The following is a description of a gene set: Any process that modulates the frequency, rate, or extent of leukocyte migration. studied in species Homo sapiens Human Gene Set: GOBP_REGULATION_OF_LEUKOCYTE_MIGRATION, and this is the list of marker genes: SPI1, MICOS10-NBL1, IL34, CD99, MIF, SLIT2 (NCBI Gene Id 9353), THBS4, GPSM3, GDF15, SMPD3, IL1R1, DAPK2, CXCR3, ADA, PIK3R1, CD81, F2RL1, RHOA, GAS6, PYCARD, DEFB124, MDK, F7, EDN3, GCSAML, CCL5, GCNT1, VEGFA, CCL3, CCL7, IL6R, CCL20, LRCH1, CCL24, MOSPD2, C1QBP, THBS1, CCL21, CD9, CCR7, S100A14, RIPOR2, BDKRB1, LGALS9, WNK1, CCL19, FUT9, ZNF580, DOCK8, BMP5, ASCL2, STAP1, MADCAM1, TNF, CCR6, PTN, JAM3, GCSAM, NF1, SPNS2, HOXA7, JAM2, FPR2, CD69, VEGFD, CORO1A, RAC2, ELANE, CCL1, ADORA1, SLAMF8, TRPV4, KITLG, EDN2, SLC8B1, WASL, CCN3, CX3CL1, CAMK1D, TNFAIP6, LBP, SELENOK, ITGA4, MIR223 (microRNA 223), CXCL13, ICAM1, MPP1, CXCL17, FADD, S100A7, CD74, PTPRJ, RIN3, PLVAP, CSF1R, MIR24-1, RAC1 (Rac family small GTPase 1), ITGA2B, CXCL10, MIR146A, SELE, RABGEF1 (RAB guanine nucleotide exchange factor 1), STK10, WNT5A, C3AR1, P2RY12, MTUS1, ADAM8, SWAP70, PERP, XCL1, ZP3, HMGB1, TNFSF18, CCL28, DDT, NCKAP1L, PTK2, LGALS3, PADI2, DUSP1, MYD88, MAPK3, C5AR2, MAPK1, TNFRSF14, BST1, CRK, DNM1L, CCL8, XG, IL27RA, RARRES2, FUT7, ADAM17, AGER (advanced glycosylation end-product specific receptor), PLCB1, DPP4, CD300A, CRKL, KLRC4-KLRK1, CD200, ADAM10, ANXA1, IL33, CHST4, TIRAP, DEFB131A, CMKLR1, NINJ1, VEGFC, AIF1, PLA2G7, EDN1, RTN4, C5, CXCL12, CX3CR1, RIPK3, P2RX4, CCR2, MIA3, CCL25, TNFRSF18, ABL1, IL6 (interleukin 6), STK39, TACR1 (tachykinin receptor 1), AKT1, MSTN, MMP28, MSN, CD47 (NCBI Gene Id 961), HMOX1, CXCL8, ADTRP, SERPINE1, GPR18, TREM2, CREB3, MMP14, MIR128-1, MED23, CCL2, CYP19A1, C5AR1, NEDD9, FUT4, MCU (mitochondrial calcium uniporter), AKIRIN1, LYVE1, CHST2, CCL4, BCR, TGFB1, GPR15LG, VEGFB, SELP, TMEM102, PTGER4, CNN2, ANO6, OXSR1, THY1, LGMN, AIRE, ECM1, PGF, CCR1, CD200R1, ITGB3, APP, APOD, IL23A, PDGFD, ITGA2, RAC3, TNFSF14, ABL2, CD99L2, ST3GAL4, IL12A, GREM1, PTK2B, SPN, CALR, P4HB, KLRK1, LYN, EMILIN1, SLAMF1, CSF1, NBL1